Given this list of marker genes SFTPA2, SFTPC, DPP9, SFTPA1, PARN, MUC5B, ATP11A, FAM13A, TERC, TERT, POT1, STN1, DSP, RTEL1, ABCA3, here is a description of the gene set: Usual interstitial pneumonia Temporal and spatial heterogeneity in lungs based on presence of fibrosis and honeycombing. Human Gene Set: HP_USUAL_INTERSTITIAL_PNEUMONIA studied in species Homo sapiens